Given this list of marker genes CD164, PDK1 (pyruvate dehydrogenase kinase 1), GRHPR, KIT, S100A14, RALGAPA2, VRK2, CALHM6, CYRIA, TTLL1 (TTL family tubulin polyglutamylase complex subunit L1), SPAG9, SEMA5B, PGAM1, ERGIC2, VIPAS39, KCTD12, TRIM39, PCP4, MPPE1, CRLF3, DDHD1, RXFP2, GALNT4, TM6SF1, METAP1D, NCR1, CHERP, KMT2D, RPS6KA3, RNPEPL1, CIC, CEP95, AP3D1, BSDC1, LETM2, STK39, ARHGAP45, ATP8B2, DNMBP, PNMA1 (PNMA family member 1), TAP1, VEZT, SKA3, SEMA3D, NACC1, GTF2IRD2, SLC14A1, CCDC85A, IPCEF1, JARID2, C19orf44, LAMA2, BORCS8, RTP4, BID, GRAMD2B, DLEU7, CD82 (CD82 molecule), TAF1C, CD96, MRPL9, EPS8L3, CCAR2, ZNF672, ACADVL, TRIM36, SURF1, TMEM37, PRPF4, C2CD3, DDA1, SYNE2, C11orf24, CAST, CLIP2, ATXN1L, SLC17A5, TCF25, SBK1, ZNF397, SLC25A53, PDHA1, ACTR2, ANTKMT, FAHD2A, TMEM181, TTLL5, MTMR1, ZNRF3, ANAPC2, SNAI3, NFKBIE, AP1G2, ERAL1, SLC17A9, NUP210, GRAMD1A, MCL1, SLC38A9, BCL7B (BAF chromatin remodeling complex subunit BCL7B), VGLL4, CMIP, CAPN15, NXF1, C9orf43, COPA, SIGIRR, ACOT4, FCGR2A, RNF31, GANAB, BUD13, TRPM4, ATP6V1F, HSF1, TXNDC11, ING2, USP20, ACRBP, GPR84, PRDM5, SCML4, B4GALT1, VEZF1, DNAJB13, HELZ2, MEI1, ATP1B4 (NCBI Gene Id 23439), CDIN1, USP40, GGA1, GPR132 (NCBI Gene Id 29933), TASOR, IQCH, UBC, LIMD1, YWHAB, MS4A2, NECAP1, RASSF2, MOB3A, PDLIM1, IFIT1, CCDC39, ANKRD39, B3GNTL1, EPHX1, KIFC2, MTA3, TREML2, CHMP2A, ACTN1, PLBD2, RPS9, SLC45A4, ATXN7, GPSM3, ARHGEF1, NCEH1, DOCK11, SPTBN1, MAP3K3, GCFC2, VMP1 (vacuole membrane protein 1), GALNT12 (NCBI Gene Id 79695), GLB1, PTGER2, EXD2, PHF1, KIAA0040, ARID1B, TIAM1, OPLAH, RPH3AL, ARAP1, PARP9, ZKSCAN5 (zinc finger with KRAB and SCAN domains 5), ST3GAL2 (ST3 beta-galactoside alpha-2,3-sialyltransferase 2), ZDHHC24, ZNF664, SHARPIN, PTPRCAP, ACVR1C, CCND3, TMEM88B, MLXIP, APPL2, HSH2D, MYCT1, ASB13, MIDEAS, EGR3, FHIP2B, ARG2, ZHX2, SLC26A6, SLC2A4RG, CHST7, PGLYRP1, AKR1C2, here is a description of the gene set: Human Gene Set: GSE8685_IL2_ACT_IL2_STARVED_VS_IL15_ACT_IL2_STARVED_CD4_TCELL_UP from publication Marzec M, Halasa K, Kasprzycka M, Wysocka M, Liu X, Tobias JW, Baldwin D, Zhang Q, Odum N, Rook AH, Wasik MA (PMID 18281483) Genes up-regulated in Sez-2 cells (T cell lymphoma): untreated versus IL15. studied in species Homo sapiens In this study we compared the effects of IL-2, IL-15, and IL-21 on the gene expression, activation of cell signaling pathways, and functional properties of cells derived from the CD4+ cutaneous T-cell lymphoma (CTCL). Whereas both IL-2 and IL-15 that signal through receptors that share the common gamma chain and the beta chain modulated the expression of >genes, IL-21 that signals via the receptor also containing gamma chain up-regulated <genes. All three cytokines induced tyrosine phosphorylation of Jak1 and Jak3. However, only IL-2 and IL-15 strongly activated STAT5, PI3K/Akt, and MEK/ERK signaling pathways. In contrast, IL-21 selectively activated STAT3. Whereas all three cytokines protected CTCL cells from apoptosis, only IL-2 and IL-15 promoted their proliferation. The effects of the cytokine stimulation were Jak3- and Jak1-kinase dependent. These findings document the vastly different impact of IL-2 and IL-15 vs. IL-21 on malignant CD4+ T cells. They also suggest two novel therapeutic approaches to CTCL and, possibly, other CD4+ T cell lymphomas: inhibition of the Jak1/Jak3 kinase complex and, given the known strong immunostimulatory properties of IL-21 on CD8+ T, NK, and B cells, application of this cytokine to boost an immune response against malignant CD4+ T cells.